The following is a description of a gene set: from publication Yevshin I, Sharipov R, Kolmykov S, Kondrakhin Y, Kolpakov F (PMID 30445619) studied in species Homo sapiens Genes containing one or more binding sites for (NR2E3) in their promoter regions (TSS -1000,+100 bp) as identified by GTRD version 20.06 ChIP-seq harmonization. Human Gene Set: NR2E3_TARGET_GENES, and this is the list of marker genes: ATPSCKMT, APBB3, FAM20B, STX7 (syntaxin 7), ADPGK-AS1, EPS8, SLC35A4, PPIB, XPNPEP1, KANSL1